Given this list of marker genes Mbp, Il1rn, Mapk7, Apoa1, Map2k5 (NCBI Gene Id 23938), Wnk1, Tnfaip3, Adipoq, Myadm, Ric8a, Il10, Klf4, here is a description of the gene set: The attachment of one cell to another cell affecting gastrulation. species: Mus musculus Mouse Gene Set: GOBP_CELL_CELL_ADHESION_INVOLVED_IN_GASTRULATION